The following is a description of a gene set: The process in which the iris is generated and organized. The iris is an anatomical structure in the eye whose opening forms the pupil. The iris is responsible for controlling the diameter and size of the pupil and the amount of light reaching the retina. studied in species Mus musculus Mouse Gene Set: GOBP_IRIS_MORPHOGENESIS, and this is the list of marker genes: Pitx2, Vhl, Foxe3, Hif1a, Hipk2, Hipk1, Pax6 (paired box 6)